The following is a description of a gene set: studied in species Mus musculus Mouse Gene Set: GOBP_REGULATION_OF_HYDROGEN_PEROXIDE_METABOLIC_PROCESS Any process that modulates the frequency, rate or extent of the chemical reactions and pathways involving hydrogen peroxide., and this is the list of marker genes: Nox4, Insr, Pink1, Nnt, Stat3, Ptger4, Mt3, Noxa1, Duoxa1, Zfp13, Prdx2, Ctns, Snca, Fyn, Mfn2, Mpv17l, Sod2, Duoxa2